The following is a description of a gene set: from publication Tassiulas I, Hu X, Ho H, Kashyap Y, Paik P, Hu Y, Lowell CA, Ivashkiv LB (PMID 15467722) Genes down-regulated in monocyte-derived macrophages primed by IFNG: untreated versus interferon alpha. species: Homo sapiens Type I IFN-inducible gene expression in human blood monocytes primed with Type II IFN. Human Gene Set: GSE1740_UNSTIM_VS_IFNA_STIMULATED_MCSF_IFNG_DERIVED_MACROPHAGE_DN, and this is the list of marker genes: HTT, PRADC1, METTL1, AFG2B, NFIC, TRAK1, SGSM3, SORT1, SNX17, ANAPC15, MAPKAPK5, USP28, ZZEF1, LIAT1, ECH1, BLTP2, AKR1B1, NCAPD3, ZER1, GTF3C5, FH, CCT7, MRPS7 (mitochondrial ribosomal protein S7), SPTAN1, FZD7, KCTD6, MAF (NCBI Gene Id 4094), ZCCHC17, TRAPPC12, GGA3, CARD9, TMEM147, NOTCH3, MTRES1, UBAC2, TMT1A, DNAAF2, GAS2L3, CENPB, ZNF765, DHX33, NOP56, TKT, LAGE3, RASL10A, CUTC, FRRS1L, APBB1IP, TRIB2, STRADA, NUP85, TMEM52B, MGME1, CYSLTR1, COMMD3, VASH1, CELF5, TUBG1, BRAT1, CTNNAL1, CHST7, VKORC1L1, ZFP36L1, MAOA, CLTB, PDCD6, FAM89B, TMEM71, TSPAN33, IRF4, SNX30, MYOT, INO80E, PREPL, KCNK6, GUF1, ABL1, UQCR10, ADI1, B3GALNT2, CISH, LMNA, NSMCE3, SLC35D1, DYRK2, SLC47A1, FBXO42, NPRL2, MCM9, EMC8, PABIR2, GGTA1, BPNT1, EEPD1, STK11, BTBD6, PALLD, SNRNP200, KCTD11, ANKRD18A, GRK3, FAM110B (family with sequence similarity 110 member B), MCRIP2, ASMTL, ZNF334, COG2, NFXL1, GGA1, EPAS1, SIGLEC17P, PPM1F, MTCP1, APEX2 (apurinic/apyrimidinic endodeoxyribonuclease 2), GNPTG, OTUD6B, JTB, RAD1, MRPL34, HNRNPUL1, SURF1, TAPT1, CEP164, HENMT1, CDK5, LMNB2, EEIG1, AGO1, KISS1R, CLEC16A, IDH3G, SPINT2, POMGNT2, ANKRD13D, CMTM8, ALKBH5, NCAPG2, ATP13A3-DT, PIK3CD, S100P, XPA, PLAGL1, MYT1L, PET117, HSD11B1, EPOP, ALOX15, NSD3, DTX4, RABEPK, CCL26, TMEM176A, TTC9C, PAGR1, ACAD9, ASB1, REEP5, MPHOSPH8, MKRN2, CCL17 (C-C motif chemokine ligand 17), HDHD5, VPS26B, TNRC6B, TMEM14C, APOO, SDF4 (stromal cell derived factor 4), TM7SF3, SLC26A6, PITPNM1, TTLL12, IL17RA, CFAP184, CERK, CHPF2 (chondroitin polymerizing factor 2), MIB2, AIFM1, MCM5, AQR, BZW2, C2orf69, UBTF, GMIP, EMB, COMMD1, TNFRSF18, SMG1P1, NDUFAF7, ZBED1, SERF2, USP21, CYC1, TNFRSF4, CCL22, RAP2A, GSTP1, PRPS1, CSK, TMEM121B